The following is a description of a gene set: Human Gene Set: GSE45881_CXCR6HI_VS_CXCR1LO_COLONIC_LAMINA_PROPRIA_UP studied in species Homo sapiens from publication Mandai Y, Takahashi D, Hase K, Obata Y, Furusawa Y, Ebisawa M, Nakagawa T, Sato T, Katsuno T, Saito Y, Shimaoka T, Yokosuka O, Yokote K, Ohno H (PMID 23840334) Genes up-regulated in colonic lamina propria cells sorted by CXCR6: high versus low. To identify the role of chemokine receptor in inflammation of colon, we isolated CD3+CD4+ helper T cells harboring CXCR6 from colonic lamina propria of mice We used microarrays to identify the differentially expressed genes between CXCR6Hi Tcells and CXCR6Lo Tcells, and this is the list of marker genes: PSME4, MSL3, TRIP12, POLR2A, CENPT, KLF12, LTBP3, BMAL1 (basic helix-loop-helix ARNT like 1), ZNF451, FOXJ3, VAMP2, ANAPC2, LINC00342, RARS1, GOLGA8B, SUSD4, IVNS1ABP, CEP83, FAM8A1, CPVL, SMC4, MACF1, APOL3, NUP205, VPS52 (VPS52 subunit of GARP complex), SLC4A7, STAG3L1, CST3, DCAF8, RINT1, PROSER1, VPS8, ZZEF1, IL1A, SLC5A3, KAT6A, SCN2B, RCOR3, ANKRD36, MAP3K4, TNIK, SV2A, LGALS8, H2AJ, CCR9, PDXDC1, IL6ST, YES1 (YES proto-oncogene 1, Src family tyrosine kinase), KIFAP3, ENTPD4, PLPPR2, ALG9, FMNL1, MIA3, MCM3AP, WDR44, POLR2B, NAA16, TMEM41B, GOLGA7, MTA1, C14orf93, ERO1A (endoplasmic reticulum oxidoreductase 1 alpha), PLXDC1, TPP2, GDI1, HNRNPH3, NFRKB, BLMH, USP24, CDK12, SVIL, MINK1, ATXN7, GOLGB1, EXOC1, IQSEC1, FUBP1, ADSS2, RASGRP1, CD302, NLRP1, HERC3, TRMO, CLIP4 (NCBI Gene Id 79745), MKRN1, IDUA, SEC61A2, FOXJ2, ANKFY1, QRICH1, GBP2, MED15, IL11RA, DOK2, SYNJ1, EOLA2, TARDBP, KLC1, AP3M2, CD40LG, PPME1, THOC2, PGAP1, VPS13A, YTHDC2, ASIC3, PRPF40A, PLEKHB2, SRP54, ZDHHC11 (NCBI Gene Id 79844), P2RX4, EML4 (EMAP like 4), APPL2, ATG16L1, NUP98, ABITRAM, ARHGEF7, HECTD3, EP300, HDC, MED23, INPP5E, RUFY2, HERC1, CRYBG1, GFER, CDC14A, PTPN13 (NCBI Gene Id 5783), STAT4, TAF1C, GLMN, DLEU2, PAFAH1B1, KIF21B, ZBTB7A, PPP2R2A, EIF3A, TENT4A, PTPRC, H1-2, CLDND1, INTS13, TTLL3, TRIM23, AAK1, PTTG1IP, PCSK7, DYRK2, ULK1, CD3E, CREBZF, KCTD13 (potassium channel tetramerization domain containing 13), MAST4, THRAP3 (NCBI Gene Id 9967), NPEPPSP1, NKTR, CACNA1I, MPHOSPH9, DCAF15, MYCBP, HDAC7, CELF2, DOP1A, GPRASP1, PHF20L1, TIAL1, MINDY3, SLC11A2, KPNA1, RBM25, UBR4, SETD1B, ENO2, IQCK, FBXO38, PARP12, NCOA2, HGSNAT, LMAN1, APBB3, SLC30A6, MARCHF6, TNKS2, SCML1, BAZ2B, MECP2, GOLGA8A, GPR63, RAPGEF6, NOTCH2NLA, TAF2, WDR55, ELMO2, SGSM2, DGKA, ARAP2, FAM193B, AREL1 (NCBI Gene Id 9870), CMAHP